The following is a description of a gene set: Human Gene Set: GSE4142_NAIVE_BCELL_VS_PLASMA_CELL_DN Genes down-regulated in naïve B lymphocytes versus plasma cells. In order to better understand the factors that regulate B cell differentiation upon exposure to antigen, we compares global gene expression profiles from naive B cells with antigen-specific plasma, germinal center, and memory B cells after immunization with the T-dependent antigen, NP-CGG. The memory B cell-enriched transcripts were then compared with memory T cell-enriched and hematopoietic stem cell-enriched transcripts in order to generate a transcriptional profile of self-renewal within the hematopoietic system. species: Homo sapiens from publication Luckey CJ, Bhattacharya D, Goldrath AW, Weissman IL, Benoist C, Mathis D (PMID 16492737), and this is the list of marker genes: BCL2L1, CHCHD3, CRTAM, ATF3, ABHD4, VPS11 (NCBI Gene Id 55976), CELSR1, HEXA, RCN1, NGLY1, ZNF281, SFXN4, CLDN16, LRRC40, CFAP210, IRAK2, AFG3L2, AKAIN1, MRPL1, FAH, TRIM68, DOCK10, ONECUT2, C6orf118, SOAT2, TM6SF1, STAG2, BIRC2, NUDT12, CEPT1, SMO, IQSEC1, PLAGL2, NUFIP1, TTC5, NCAPG, RAD51B, IFI44L, KBTBD11, TBKBP1, TACR2, CMTM8, LSR, PPIL3, ADAM8, WASL, CARNS1, PEX1, DNAJC21 (NCBI Gene Id 134218), EGR1, VPS26C, CPSF6, MFSD2A, TMOD1, MLLT3, REN, PADI3, CDS1, ZFP82, FABP2, MIEF2, TANC2, PYGM, CCDC18, GJB6, CALU, TBC1D2B, FUCA2, FPGT, CSNK1A1, ADAMTSL4, GTDC1, ZFPM1, CEP72, MTMR14, GSTT1, PTGER2, CASS4, IL12RB2, CDK17 (NCBI Gene Id 5128), RREB1, GATA3, LRIF1, FAT2, INSM1, DAB2IP, ARMC10, SLC17A6, ARHGAP15, NAPSA, EPHX1, C16orf86, GNPNAT1, TMEM229B, UFL1, CHID1, RIOK1, PGM3, PROX2, CYB5R2, ZNF29P, MAN1C1, PPM1E, PLXNB2, P2RX7, CPT2, EGR4, FGFBP1, MTA1, ASL, HLTF, ZMAT3, ACAA1, LYPD6B, ITGB5, BMP10, SECTM1, TRMO, DENND2D, RALGPS2 (Ral GEF with PH domain and SH3 binding motif 2), GPD2, LMX1B, TPST2, TP53I11, CXorf38, MUTYH, VRK2, IFIH1, ZNF708, ZNF341, ZMYM4, TBC1D7, HJURP, ARID4A, VILL, MLKL, PPWD1, GARIN3 (golgi associated RAB2 interactor family member 3), ARHGAP18, GOLGA3, HADH, RND3, LHX2, ETV6, SH3GL3, TMEM248, HS3ST4, CD5, NADSYN1, BABAM2, TRIM5, MAP2K1, ORMDL1, UAP1L1, MTHFD1L, LEPR, WDR81, RILPL2, GIMAP6, KPNA6, N4BP2, VPS39, PPARG, GPR132, CCDC184, CD82, TXNL1, ATP8B4, GIMAP8, SEC24C, UBE2W, KCTD16, PLCD4, NEMF, EML5, PELI1, HBG2, COG3, PMS1, POLD1, PKN2, GSTT2 (glutathione S-transferase theta 2 (gene/pseudogene), NCBI Gene Id 91334), IFT172, CTC1, CD200, STRBP, ROCK1, FAM107B, PLRG1, VBP1, SH3BP1, PANK2, USP2, ATP11B, SLC23A3, ELF4, ARID2, APAF1, GRM1, NCOA3